The following is a description of a gene set: The removal of phosphoric residues from peptidyl-O-phospho-L-serine to form peptidyl-serine. species: Mus musculus Mouse Gene Set: GOBP_PEPTIDYL_SERINE_DEPHOSPHORYLATION, and this is the list of marker genes: Dusp1, Pptc7, Ppp3ca, Ppp2r1a, Ppm1f, Ppp5c